The following is a description of a gene set: IRAK-4 is an essential component of the signal transduction complex downstream of the IL-1- and Toll-like receptors. Though regarded as the first kinase in the signaling cascade, the role of IRAK-4 kinase activity versus its scaffold function is still controversial. In order to investigate the role of IRAK-4 kinase function in vivo, ‘knock-in’ mice were generated by replacing the wild type IRAK-4 gene with a mutant gene encoding kinase deficient IRAK-4 protein (IRAK-4 KD). Analysis of bone marrow macrophages obtained from WT and IRAK-4 KD mice with a number of experimental techniques demonstrated that the IRAK-4 KD cells greatly lack responsiveness to stimulation with the Toll-like receptor 4 (TLR4) agonist LPS. One of the techniques used, microarray analysis, identified IRAK-4 kinase-dependent LPS response genes and revealed that the induction of LPS-responsive mRNAs was largely ablated in IRAK-4 KD cells. In summary, our results suggest that IRAK-4 kinase activity plays a critical role in TLR4-mediated induction of inflammatory responses. Human Gene Set: GSE9037_CTRL_VS_LPS_4H_STIM_BMDM_DN from publication Koziczak-Holbro M, Glück A, Tschopp C, Mathison JC, Gram H (PMID 18266302) species: Homo sapiens Genes down-regulated in comparison of untreated macrophages at 4 h versus those treated with LPS (TLR4 agonist) at 4 h., and this is the list of marker genes: MYEF2, CASP7, MATCAP1, SLC32A1, PPP3CC, TMEM243, CSF3, RFTN1, REPS1, SPI1, FOXP1, PPP1R15B, KBTBD8, FZD1, CRYBA1, MSR1, LRP10, CDKN2B, PSMA3, C10orf88, KATNBL1 (katanin regulatory subunit B1 like 1), ERBIN, FBRS, DGAT2, SCYL2, USO1 (NCBI Gene Id 8615), MAIP1, KLF3, MXD1, PTPRK (NCBI Gene Id 5796), CAMP, PSMA7, ATXN7, ANKRD17, PNPT1, MAN2A1, GLIPR1, MECR, AFTPH, NGLY1, RPL24, MYO9A, PLEKHA5, PPIG, DNAJB5, CTU1, OR51B2, HACD3, HLA-DOA, USP25, NOB1, CCDC43, EPC2, C14orf28, ARHGAP23, DYRK1A, MOB3C, NOP58, IL6ST, MRPL50, TRPM4 (NCBI Gene Id 8184), PILRA, GRAMD2B, MPC1, CHD2, SHMT2, PWP1, TAP2, MED17, DDX60, HAPSTR1, SPOCK2, CREB5, PPFIA1, FYB1, TBRG1, SPINDOC, HVCN1, KCNE4, AP3B1, ATG2A, PHGDH, EME2 (essential meiotic structure-specific endonuclease subunit 2), IL36A, INO80D, TMBIM4, BMAL1, SLC30A1, ITGAL, TMCC3, STAU1, CYP2C8, CCDC38, OSM, CD27, TFAM, NPHS2, IGFLR1, GREM2, DNAJC21, UBE2Z, TIMM10, SNIP1, SLC30A6, ODC1, ANKRD42, PRRC2B, SLFN12, MRPS18B, CLOCK, CES3, APIP, BRD2, TSG101 (NCBI Gene Id 89764), BCL6B, PPRC1, CRABP1, NFXL1, ENPP2, RNF135, ZC3HC1, PSIP1, GADD45A, AZI2, WASHC4 (NCBI Gene Id 23325), FXR2, RASA2, CDHR4, FXR1, ANKRD11, PEX11A, NDUFS4, PRPF38A, GRWD1, GCA, INHBA, CLCN7, SPRY4, PNP (NCBI Gene Id 4860), IFIT1, UTP15, ZNF771, TIMP1, DUSP16, GTF2H1, RASGEF1A, RNF145, PARP8, CASP1, PDCD10, GNL3, CARMIL1, SH3TC1 (SH3 domain and tetratricopeptide repeats 1), VWA1, CABLES2, CERS6, DCP2, SLC28A2, POLR1F, IPPK, MINDY3, SLC20A1, SFMBT1, GPR25, NCOR1, CEPT1, LARP4B, AGO1, CNMD, HCLS1, ST7, MTERF3, SRP54, MIR22HG, IL4R, PSMA2, CFAP251, CAMKV, SRSF10, CLDN12, C3, SUB1, VTI1A, STAT1, LRRC8D, CTPS1, ZNF654, PPM1B, OSBPL3, UNC80, DLX1, SLC35E4, MICU3, DNAJA2, PODXL2, USB1, SETD5, STARD7, KMT2A, ZC3H15